Given this list of marker genes TUBGCP3, PHYHIPL (phytanoyl-CoA 2-hydroxylase interacting protein like), TEAD1, MTMR1, RAB10, GABBR2, RAP2A, NAB1, SMAP1, IPO7, ENAH, CLEC16A, RALGAPA1, LRRC8A, PHF2, KIDINS220, HMBOX1, ABI2, UBQLN1, ZFP14, SOX5, SPAG9, ADO, CEP350, ZFAND3, TMEM30A, CCDC88A, RAN, FBXW11, NGRN, CLASP2, SNX27, CAND1, SPIRE1, here is a description of the gene set: Human Gene Set: GCM_RAP2A studied in species Homo sapiens Neighborhood of RAP2A Neighborhood of RAP2A RAP2A, member of RAS oncogene family in the GCM expression compendium